The following is a description of a gene set: studied in species Homo sapiens Human Gene Set: REACTOME_CYTOSOLIC_IRON_SULFUR_CLUSTER_ASSEMBLY Cytosolic iron-sulfur cluster assembly, and this is the list of marker genes: RTEL1, CIAO2B, BRIP1, CIAPIN1, NUBP1, NDOR1, NUBP2, MMS19, CIAO1, ERCC2, POLD1, CIAO3, ABCB7 (ATP binding cassette subfamily B member 7)